Given this list of marker genes ORC1, CBFB, FLNA, CYP27B1, DYNC2I1, EIF2AK3, COL9A3, DHCR7, TSHR, PIGV, TRPV4, PEX26, FGFR2, COMP, THRB, EXTL3 (exostosin like glycosyltransferase 3), IHH, NFIX, GSC, PEX16, EXOC6B, NANS, PRKAR1A, ACVR1, TRIP11, DNAJC21, AGPS, SBDS, DLK1, BMPER, RNU4ATAC, PAM16, GJB6, SOX9, SETD2, PEX11B, CYP2R1, GPC4, RTL1, LHX4, PISD, ABCC6, COL1A2, NKX3-2, IYD, LHX3, PROP1, SLC35B2, WNT3, IARS2, CLCN5, ORC6, RMRP, MBTPS1, SLC5A5, GPX4, PEX2, CHST3, RUNX2, SLC26A2, GGCX, NEU1, PEX3, TSHB, MEG3, CD96, PEX14, TONSL, ALPL, DUOXA2, INPPL1, GDF5, GNPAT (NCBI Gene Id 8443), NSD2, BGN, DYM, RSPO2, PEX5, MGP, PTH1R, BMPR1B, HOXA13, TBX4, CPLX1, LBR, CSPP1, DDRGK1, PEX6, PEX7, TG, PEX13, PEX19, CTBP1, DYNC2I2, LEMD3, GJB2, COL10A1, IFT80, HESX1, ENPP1, DYNC2H1 (dynein cytoplasmic 2 heavy chain 1), TPO, VAC14, FIG4 (NCBI Gene Id 9896), GUSB, SLC34A3, KIAA0586, FGFRL1, NSDHL, B3GALT6, MATN3, UFSP2, LFNG, TRAPPC2, KIF22, SLC35D1, SLC34A2, ARSL, SIK3, CYP19A1, SLC10A7, COL1A1, FLNB, COL2A1, P4HB, LETM1, SRP54, CANT1, SNRPB, PEX12, WDR35, PEX1, LONP1, KIF7, VDR, POU1F1, KCNH1, COL11A2, PDE4D, XYLT1, ESR1, EBP, PEX10, MIR140, VPS35L, GPC3, DDR2, PTCH1, DUOX2, HSPG2, here is a description of the gene set: species: Homo sapiens Abnormal enchondral ossification Human Gene Set: HP_ABNORMAL_ENCHONDRAL_OSSIFICATION An abnormality of the process of endochondral ossification, which is a type of replacement ossification in which bone tissue replaces cartilage.